The following is a description of a gene set: Any process that modulates the frequency, rate or extent of tRNA metabolic process. Human Gene Set: GOBP_REGULATION_OF_TRNA_METABOLIC_PROCESS studied in species Homo sapiens, and this is the list of marker genes: METTL1, NSUN2, TRDMT1, AKT1, RNH1